The following is a description of a gene set: species: Homo sapiens Catalysis of the reaction: S-adenosyl-L-methionine + tRNA = S-adenosyl-L-homocysteine + tRNA containing methylcytosine. Human Gene Set: GOMF_TRNA_CYTIDINE_METHYLTRANSFERASE_ACTIVITY, and this is the list of marker genes: NSUN2 (NCBI Gene Id 54888), METTL6, NSUN3, FTSJ1, METTL8, NSUN6, METTL2B, METTL2A, TRDMT1